The following is a description of a gene set: from publication Victora GD, Schwickert TA, Fooksman DR, Kamphorst AO, Meyer-Hermann M, Dustin ML, Nussenzweig MC (PMID 21074050) species: Homo sapiens Genes up-regulated in B cells: light versus dark zone. Human Gene Set: GSE23925_LIGHT_ZONE_VS_DARK_ZONE_BCELL_UP Microarrays of gene expression in mouse germinal center B cells photoactivated in the light zone or dark zone, and of naïve cells for comparison. We used microarray data to identify genes differentially expressed by B cells in the light and dark zones of the germinal center., and this is the list of marker genes: ATXN1L, PRSS21, EYA4, BOLA2, KCND1, MAN1A2, CBR3, P2RX7, ITPK1 (NCBI Gene Id 3705), MYH9, BMPR2, ANTXR2, ZCCHC12, TMEM126A, SLC31A1, LMF1, REEP4, CACNG2, ZNF703, CLPB (NCBI Gene Id 81570), SLC7A8, ATP2A3, NDP, CPSF4, FAM193A, ANGEL1 (angel homolog 1), CMIP, C19orf25, RARRES1, L3MBTL2, AEBP1 (NCBI Gene Id 165), SRSF1 (NCBI Gene Id 650453), MDH1, DSCC1, ZNF777, SFTPD, EIF2B1, GREB1L, SERPINA11, TREML4, SAMD1, NT5E, KCNK4, HIGD1C, BRMS1, PTBP3, FUOM, SV2B, WASF3, KIF26A, CNOT11, CLDN3, CYP4A22, RTL8B, PLA2G15, CELA1, VAMP5, ERICH2 (NCBI Gene Id 650047), C8B, BOK, GSTM4, CRISPLD2, ZNF362, SDCBP2, INPP5K, SYT12, NTRK3, OPTN, NUCKS1, NUDT11, SLC1A4, RSBN1, SLC30A9, C11orf91, DMBX1 (diencephalon/mesencephalon homeobox 1), VSX1, OSBPL3, TMEM43, RGCC (regulator of cell cycle), GABRR2, RPA1, TMEM132D, STX4 (syntaxin 4), SLC25A1, TRIM35, CNFN, RBM47 (RNA binding motif protein 47), CLDN5, PCDHB16, LPP, CES4A, H1-0 (H1.0 linker histone), CTNND1, PSKH1, SLC45A4, RAMP1, ZNF711, CFAP20DC, WDR26, MRGPRE, KRTAP12-2, KLHL4, ELFN2, GRIN3B, SPRED2, NIPAL1, AARSD1, WDR73, IGFLR1, SCYL1, SLC30A10, CCPG1, SLC22A9, OSBPL9, TGFB3, SEC16B, TCTA, PTPN5, NPEPL1, EFS, SLC38A10, HSPA2, EDN3, C1orf185, TCF23, DLGAP1-AS1, RAB3IL1, LAMP2, ZNF839, ATG13, PYROXD1, DRAM1, SLC36A4, ARRB1, SAE1, FBXL16, RDH16, KLHL36, PCP4, CRTAP, INSYN2A, PXMP4, PLXNB1, ATN1, DRG1, EVX1, KCNG1, RBFOX1, NT5DC3, STK39, EFNA5, ANGPTL8, PDLIM7, FAM43A, BAG4, SNN, AMDHD1, GALNS, MAP4, ADCY5, NHERF1, TBX5, CFL1, CACNA1E (NCBI Gene Id 777), GSTM5, ANKH, TF, LANCL1, PLCL2, TMEM241, MIS18A, SYT1, PXN, KLHL29, TNFRSF18, DDX25, ACLY, PDZD4, RGS7BP, GPR85, TIMP4, ADAMDEC1, KCNJ6, DHDH, SLC35E4, STON1, HEXA, AKAP6, SDCBP, BTRC, KCTD1, RASGRP3, ABCD1, REXO2, APOE, CERS6, AANAT, ZBTB7A, LRP10